The following is a description of a gene set: Human Gene Set: HP_HYPERKINETIC_MOVEMENTS Motor hyperactivity with excessive movement of muscles of the body as a whole. Hyperkinetic movements studied in species Homo sapiens, and this is the list of marker genes: YME1L1, SCN2A, ZNF142, THOC2, SUCLA2, SYT1, VPS13A, RTTN, CACNA1B, SLC9A6, NEUROD2, GRIN1, PTS, PSAP, NEUROG1, MTRR, PYCR2 (NCBI Gene Id 29920), ALDH5A1, IQSEC2, PNKD, BCKDK, GNAO1, CAMK2B, HSD17B10, PDE10A, SCN1A (sodium voltage-gated channel alpha subunit 1), GNE, LETM1, PRRT2, WARS2, NGLY1, GRIN2A, CLPB, CACNA1E, SLC6A3, GCH1, TRAPPC11 (trafficking protein particle complex subunit 11), GAD1, FBXL4, SUCLG1, FRRS1L